Given this list of marker genes SPIN1, RGMB, CRABP2, CNGA2, DMAC1, HSD11B1L, LMO4, IZUMO4, SORCS2, BTBD9, CAPZA2, PIK3CG, IL9R, KCNJ11, ELK1, LAD1, CHODL, SLC30A7, HDC, SLC46A1, ARHGEF11, FPR2, PRICKLE1, MEF2A, NOS1, TMEM9, GLIPR1L2, CRYM, PCDHB4, UBE3A, MYD88, HLA-DPB1, PRR5L, KCTD6, AIF1L, ATG10 (NCBI Gene Id 83734), CSRNP1, TMTC2, ABHD2, GPR146, ANP32A, SOCS5, GOPC, TET3, PDS5A, ZNF749 (NCBI Gene Id 388567), FYN, WDR72, PKLR, DMC1, TRAK2, PDXP, METTL15, PPP2R5E, RCHY1, SYNGR3, SH3KBP1 (NCBI Gene Id 94010), PRDM2 (NCBI Gene Id 82680), ERLIN2, PNMA1, NKAIN1, SATB2, RFT1, VSX2, MEF2D, ACAP3 (NCBI Gene Id 80855), RBFOX2, ZNF217, RABL3, MAU2, HNRNPD, AMER3, LRP2BP, CARD8, ZNF609, RUBCN, FBXO30, CLCN7 (NCBI Gene Id 7814), PRORP, IFFO1, SQSTM1 (sequestosome 1), ATP6V0E2, here is a description of the gene set: Human Gene Set: MIR211_3P Genes predicted to be targets of miRBase v22 microRNA hsa-miR-211-3p in miRDB v6.0 with MirTarget v4 prediction scores > 80 (high confidence targets). from publication Chen Y, Wang X (PMID 31504780) studied in species Homo sapiens